Given this list of marker genes HAS3, SDC4, LIF, RNF44, IER2, PPIP5K1, ARNT, SHISA7, IL1RAPL1, USP9X, BAIAP2, HTR7, DND1, VANGL2, KLHL18, SUGP2, YES1, HMGN2P46, HMGN2, TMEM121B, LAMTOR1, CSNK1G1, ZDHHC9, TP53INP1, CHRD, ZMYND11, MCMBP, IL16, CHD6, SGCD, CNTFR, PRKAR2A, RREB1, MNT, AMMECR1L (NCBI Gene Id 83607), EPB41, DBNDD1, KLF13, GATA3, H3-3B, NFIX, ATP1B4, PURB, CDK16, SAMD11, OGT (NCBI Gene Id 8473), POLR3E, CAMK2G, BACH2, FZD7, ZNF608, SLC25A22, CHD3, FXR2, USP2, SH2D3C, PCDH10, SORT1, SMPD3, NRF1, STC1, CTDSPL, ELOVL6, LINGO2 (leucine rich repeat and Ig domain containing 2), GPC4, PALM2AKAP2, PAN2, IKZF4, H3-5, MMD, PCDH1, GRM3, PCDH17, CEP170 (NCBI Gene Id 9859), ILRUN, SOHLH1, CNOT6, MECP2, DCX, RRAGC, COPS7B, POMT2, KDM1B, CDIP1, here is a description of the gene set: species: Homo sapiens Human Gene Set: CAGGGTC_MIR504 Genes having at least one occurence of the motif CAGGGTC in their 3' untranslated region. The motif represents putative target (that is, seed match) of human mature miRNA hsa-miR-504 (v7.1 miRBase).